The following is a description of a gene set: Genes predicted to be targets of miRBase v22 microRNA hsa-miR-6865-5p in miRDB v6.0 with MirTarget v4 prediction scores > 80 (high confidence targets). from publication Chen Y, Wang X (PMID 31504780) studied in species Homo sapiens Human Gene Set: MIR6865_5P, and this is the list of marker genes: ZNF214, PSMB5, FADS1, PTGFRN, ZSWIM5, CCDC25, DCUN1D4, PIANP, UBL4A, ZNF124, TBP, GOLM1, CA7, EPHB1, ATXN7, ZC2HC1B, ABR, DLG1, GALNT4, POC1B-GALNT4, FAM76B, MED12L, VSIG10L, FLT3, RAB10, PLEKHM3, DNAJB6, TMEM52B, ISY1-RAB43, CAMTA1, SPECC1, UNC13D, ZNF367, RNF125, NIP7, RAB43, PRKCI, CHD5, ARFGEF2, ATP9A, PALLD, SNCAIP, VGLL3, GLO1, CPEB2, BBOF1, IDH1, AK9, ACY3, XKR9, STXBP3, DUOXA1, DCX, GCH1, IFT57, ATP10B, MYO9A, TOR1B